The following is a description of a gene set: Mouse Gene Set: GOMF_INTRACILIARY_TRANSPORT_PARTICLE_B_BINDING studied in species Mus musculus Binding to an intraciliary transport particle B (IFT B) complex., and this is the list of marker genes: Kif3a, Kif3b, Ift70a1, Ift70b, Ift70a2, Ift56, Kifap3